The following is a description of a gene set: from publication Chen Y, Wang X (PMID 31504780) species: Mus musculus Genes predicted to be targets of miRBase v22 microRNA mmu_miR_3473h_5p in miRDB v6.0 with MirTarget v4 prediction scores > 80 (high confidence targets). Mouse Gene Set: MIR_3473H_5P, and this is the list of marker genes: Clrn3, Tnfsf12, Syt6, Cdk19, Trem4, Fasl, Mark1, Tob2, Phka2, Cadm3, Eef1e1, Frmd4a, Ndufs2, Chrna4, Zfp60, Grem2, Cntrl, Kcnn2, Laptm5, Acsf2, Apln, Rab9b, Esr1, Pkm, Dcstamp, Htr3a, Tor1aip2, Adgrd1, Pycr1, Zfp607b, Mapkbp1 (mitogen-activated protein kinase binding protein 1), Itsn1, Fdx1, App, Snx12, Usp35, Zfhx4, Syt1, Syp